Given this list of marker genes WT1, PKD2, LHX1, BASP1, FOXJ1, CALB1, here is a description of the gene set: The development of the portion of the ureteric bud tube that contributes to the morphogenesis of the metanephros. Human Gene Set: GOBP_METANEPHRIC_PART_OF_URETERIC_BUD_DEVELOPMENT studied in species Homo sapiens